The following is a description of a gene set: studied in species Mus musculus Mouse Gene Set: GOMF_HIGH_VOLTAGE_GATED_CALCIUM_CHANNEL_ACTIVITY Enables the transmembrane transfer of a calcium ion by a high voltage-gated channel. A high voltage-gated channel is a channel whose open state is dependent on high voltage across the membrane in which it is embedded., and this is the list of marker genes: Cacna1a, Cacna1f, Cacna1b, Cacnb1, Cacna1d, Cacnb3, Cacna1e, Cacna1s, Cacnb2, Cacna1c, Cacnb4